The following is a description of a gene set: studied in species Mus musculus from publication Stark KL, Xu B, Bagchi A, Lai WS, Liu H, Hsu R, Wan X, Pavlidis P, Mills AA, Karayiorgou M, Gogos JA (PMID 18469815) Genes up-regulated in hyppocampus of mice carrying a hemizygotic microdeletion in the 22q11.2 region. Individuals with 22q11.2 microdeletions show behavioral and cognitive deficits and are at high risk of developing schizophrenia. We analyzed an engineered mouse strain carrying a chromosomal deficiency spanning a segment syntenic to the human 22q11.2 locus. We uncovered a previously unknown alteration in the biogenesis of microRNAs (miRNAs) and identified a subset of brain miRNAs affected by the microdeletion. We provide evidence that the abnormal miRNA biogenesis emerges because of haploinsufficiency of the Dgcr8 gene, which encodes an RNA-binding moiety of the 'microprocessor' complex and contributes to the behavioral and neuronal deficits associated with the 22q11.2 microdeletion. Mouse Gene Set: STARK_HYPPOCAMPUS_22Q11_DELETION_UP, and this is the list of marker genes: Mtmr4, Tfrc, Vamp2, Neto1, Usp7, Ywhag, Fjx1, Ids, Camkk2, Dclk1, Epas1, Mir22hg (Mir22 host gene (non-protein coding)), Trak1, Cntnap1, Papola, Rph3a, ENSMUSG00000144058, Cpeb4, Cx3cl1, Mirg, Rcc2, Hnrnpu, Fbxw11, Olfml2b, Mirlet7b, Zfp445, Spin1, Dlg2, A330023F24Rik, Ap2a2, Atp13a2, St3gal2, Gpr68, Cnnm1, Atp6v0a1, Grin2b, Gpd1l, Slc17a7, Aak1, Peak1, Grk2, Emc10, Dleu2, Aopep, Rab6b, Sort1, Kbtbd11, Clec16a, Uvrag, Efr3a, B3gat1, B4galt6, Mir9-2hg, Stxbp1, Pcnx1, Cdk5r1, Bsn